The following is a description of a gene set: studied in species Homo sapiens Catalysis of the concomitant phosphorylation of threonine (T) and tyrosine (Y) residues in a T-X-Y motif in the activation loop of a MAP kinase (MAPK) substrate. Human Gene Set: GOMF_MAP_KINASE_KINASE_ACTIVITY, and this is the list of marker genes: MAP2K7, MAPKAPK5, SBK2, PAK3, MAP2K6, BRAF, MAPKAPK3, MAP2K2, MAP2K5, MAPK14, MAP3K9, MAP2K1, PBK, MAPK10, MAP2K3, MAP2K4